The following is a description of a gene set: Malar rash species: Homo sapiens An erythematous (red), flat facial rash that affects the skin in the malar area (over the cheekbones) and extends over the bridge of the nose. Human Gene Set: HP_MALAR_RASH, and this is the list of marker genes: BLM, PXK, PDCD1, IRAK1, TNFAIP3, CASP10, FCGR2A, TNIP1, FCGR3B, HLA-DRB1, FCGR2B, PTPN22, UBE2L3, IRF5, IGHG1, C4A, CR2, ITGAM, KIAA0319L, MECP2, BANK1, C1QB, BLK, DNASE1, STAT4, TNFSF4, SPP1, SAT1, CBS (NCBI Gene Id 875), IL10, C4B, TLR7, TREX1, TOP3A, ETS1, STING1, CDK10, JAZF1, CTLA4